Given this list of marker genes CD47, WNT4, PFN2, TGFBR1, ARHGEF15, RAC1, RHOA, BAG4 (BAG cochaperone 4), CCN2, NF2, MTOR, RGCC, SFRP1, TACR1, RAPGEF3, TAC1, ABL1, SORBS3, ARHGEF10, PPM1F, PFN1, BRAF, ARHGEF5, PFN3, CDC42, S100A10, CARMIL1, TESK1, PLEK, NRP1, SWAP70, PAK1, APOA1, VIL1, RHOC, LPAR1, SYNPO2L, FHOD1, SYNPO, MYOC, CCDC88A, CX3CL1, GPR65, EVL, LIMCH1, ARHGEF10L, SYNPO2, LIMK1, SERPINF2, TGFB3, PXN, SMAD3, SDC4, TPM1, MTSS1, ITGB1BP1, FERMT2, FLNA, AMOT, ROCK2, PPM1E, EPHA1, here is a description of the gene set: studied in species Homo sapiens Any process that activates or increases the frequency, rate or extent of the assembly of actin filament bundles. Human Gene Set: GOBP_POSITIVE_REGULATION_OF_ACTIN_FILAMENT_BUNDLE_ASSEMBLY